Given this list of marker genes IFT20 (NCBI Gene Id 90410), PAX2, MYO3B (NCBI Gene Id 140469), EPHA4, NECTIN3, POU3F4, GRHL3, CDH23, TBX18, RAC1, ADAM10, CTHRC1, PTK7, GATA2, DVL1, SOX9, PAFAH1B1 (platelet activating factor acetylhydrolase 1b regulatory subunit 1), SLC26A5, DCANP1, ZEB1, SLITRK6, VANGL2, TIFAB, MYO7A (myosin VIIA), EYA1, TBX2, CCNA2, DVL2, SOBP, DCHS1, MCM2, CECR2, TBX1, HES1, GABRB2, KCNQ1, GABRA5, GATA3, MYO3A, SLC17A8, FRZB, NEUROG1, NTRK3, HOXA1 (homeobox A1), RPGRIP1L, KCNK2 (NCBI Gene Id 3776), GRXCR1 (NCBI Gene Id 389207), GABRB3, SIX1, KCNK3, WNT5A, HPN, HEY2, FZD2, IFT27, NECTIN1, CALB1, here is a description of the gene set: studied in species Homo sapiens The progression of the cochlea over time from its formation to the mature structure. The cochlea is the snail-shaped portion of the inner ear that is responsible for the detection of sound. Human Gene Set: GOBP_COCHLEA_DEVELOPMENT